Given this list of marker genes CORO1A, HIP1R, PICK1, DNAI3, CTNNA2, CORO1B, GMFB, GMFG, ARPIN, here is a description of the gene set: species: Homo sapiens Human Gene Set: GOBP_NEGATIVE_REGULATION_OF_ACTIN_NUCLEATION Any process that stops, prevents, or reduces the frequency, rate or extent of actin nucleation, the initial step in the formation of an actin filament in which actin monomers combine to form a new filament.